The following is a description of a gene set: Any process that activates or increases the frequency, rate or extent of striated muscle contraction. Mouse Gene Set: GOBP_POSITIVE_REGULATION_OF_STRIATED_MUSCLE_CONTRACTION studied in species Mus musculus, and this is the list of marker genes: Ccn2, Actn3, Kcnq1, Ucn, Mylk2, Ace2, Nppa, Smtn, Rgs2, Atp1a1, Trpv4, Adra1a, Chga, Hsp90aa1, Atp2a1